Given this list of marker genes Cul3, Cct7, Tra2b, Rhobtb1, Txnl1, Spen, Pde5a, Hnrnpc, Srrm1, Cops4, Vim, Rnf20, Rock2, Myo6, Cops2, Stk38, Rbbp6, Cct2, Cpsf7, Gps1, Rbmx, Rock1, here is a description of the gene set: RHOBTB1 GTPase cycle Mouse Gene Set: REACTOME_RHOBTB1_GTPASE_CYCLE studied in species Mus musculus